Given this list of marker genes Rgs2, Junb, Ppp1r15a, Klf6, Jun, Fos, here is a description of the gene set: from publication Cui A, Huang T, Li S, Ma A, Pérez JL, Sander C, Keskin DB, Wu CJ, Fraenkel E, Hacohen N (PMID 38057668) Mouse Gene Set: CUI_T_CELL_CD4_ADIPONECTIN_RESPONSE_DN Genes negatively differentially expressed in cell type: CD4+ T cell upon treatment with cytokine: AdipoQ in mouse lymph nodes in vivo. Cytokines mediate cell-cell communication in the immune system and represent important therapeutic targets. A myriad of studies have highlighted their central role in immune function, yet we lack a global view of the cellular responses of each immune cell type to each cytokine. To address this gap, the authors created the Immune Dictionary, a compendium of single-cell transcriptomic profiles of more than 17 immune cell types in response to each of 86 cytokines (>1,400 cytokine-cell type combinations) in mouse lymph nodes in vivo. A cytokine-centric view of the dictionary revealed that most cytokines induce highly cell-type-specific responses. For example, the inflammatory cytokine interleukin-1β induces distinct gene programmes in almost every cell type. A cell-type-centric view of the dictionary identified more than 66 cytokine-driven cellular polarization states across immune cell types, including previously uncharacterized states such as an interleukin-18-induced polyfunctional natural killer cell state. species: Mus musculus